Given this list of marker genes Rad9b, Atf2, Eme2, Hus1, Tipin, Hus1b, Rad9a, Msh2, Nek11, Eme1, Fancd2, Mus81, Mre11a, Rad17, Chek2, Xpc, here is a description of the gene set: A mitotic cell cycle checkpoint that slows DNA synthesis in response to DNA damage by the prevention of new origin firing and the stabilization of slow replication fork progression. studied in species Mus musculus Mouse Gene Set: GOBP_MITOTIC_INTRA_S_DNA_DAMAGE_CHECKPOINT_SIGNALING